The following is a description of a gene set: studied in species Homo sapiens from publication Chen Y, Wang X (PMID 31504780) Human Gene Set: MIR4766_5P Genes predicted to be targets of miRBase v22 microRNA hsa-miR-4766-5p in miRDB v6.0 with MirTarget v4 prediction scores > 80 (high confidence targets)., and this is the list of marker genes: MTMR4, NELL2 (neural EGFL like 2), RB1CC1, RFX3, CDK12, SH3BGRL2, SOX6, HIF1AN, INO80D, NOL4, ADAMTS17, PDLIM3, ELF1, SLCO6A1, SLC38A1, PARPBP, BAG5, SCAI, GUCY1B1, ZNF681, ATXN7, SLC18A1, FZD3 (NCBI Gene Id 7976), PRR23C, RTKN2, HCAR2, EPB41L2, CMKLR2, C8orf33 (chromosome 8 open reading frame 33), MORC1, SCUBE3, PKHD1L1, FAM210A, TLR5, OSTM1, LRCH2, RFXAP, ZNF350, CDK13, WNK3, GNE, UBIAD1, RTF1, PIGV, AMOT, ADD3, PHIP, AKAP11, TRANK1, FGFR2, SPRED1, SEMA3A, IDS, AAK1, TNKS2, STAM2, C5orf22, CSTB, GOLGB1, TMEM26, CEMIP, SPTY2D1, LNX2, SLX4IP, BCL10, PLCXD3, ZDBF2, GATAD2B, KCNA7, RCN2, ZNF626, KALRN, HMG20A, TTPA, BBX, CHD9, GOT2, KLHL14, ACADSB, CGGBP1, NCOA2, DPYS, RHOQ, MBLAC2, TAF9B, ARV1, REPS2, PHF20L1, WBP1L, FAM221B, SBSPON, ATP6V0A2, ATXN1, RAB22A, SASH1, PI15, C6orf62, RUNDC3B, SPICE1, TMEM263, IFT20, TFB2M, ZNF516, GAS7, TLN2 (NCBI Gene Id 83660), TOP1, VGLL3, DHTKD1, NSL1, GCOM1, PCDHGA11, ZMYND8, SLC1A3, ACTBL2, CADM2, ECT2L, DIP2B, TUBGCP3, DCDC2, TRIM13, RBM25, AR, SUPT20H, RPRD1A, MLLT10, BASP1, CLVS2, ACTN4 (NCBI Gene Id 81), SLFNL1, PAM, MARCHF6, ZFP90 (NCBI Gene Id 146198), XYLT1 (NCBI Gene Id 64131), GNB4, NSUN7, LCORL, TRIM14, OCLN, HOOK3, HPGDS, ZBTB20, LRP6, NNT, B3GALT1, SLC44A1, DNAJB3, MYBL1, IFIT2, FIGN, RND3, SNX27, AFF4, FTHL17 (ferritin heavy chain like 17), KICS2, ZNF236, SNX16 (sorting nexin 16), PPM1G, CREBRF, POU4F2, RASAL2, IFT81, SCAF11, GLYR1, AGBL3, ZNF195, ARL13B, SANBR, ARHGAP28, CBX5 (chromobox 5), UNC5D, ROBO1, KMT5B, CYB5R3, MAPK1IP1L, C14orf28, KCNN2, MGAT4A, BIRC5 (baculoviral IAP repeat containing 5), TMEM132D, MEMO1, FZD4, PRKACB, C21orf91, TMEM237, IMPACT, ZNF26, SH3PXD2A, PLEKHA1, STMP1, GPR158, MAP7D3, HLF, ZNF322, SIX4, MEIOC, BMPR1A, VEPH1, P2RY13, RBM4, GNAL, CDKL4, MYO3B, PAPLN, ZNF92, GLI3, SLC66A3, DOCK10 (dedicator of cytokinesis 10), ADAMTSL1 (NCBI Gene Id 92949), DDX20, MCTP2, ZFP36L1, AFF3, KLHL15, SYT14, CLGN, FAM98A, HYCC2, AUTS2, TRAM1, CHRNA4, TAOK1, DNAI4, HCAR3, NCKAP5, EEIG2, BACE1, RASA4, UTP25, ZBTB44, GUCY1A2, BOD1L1, PRDM10, GPBP1, TAF4, AMMECR1, PRR9, NACC2, SMG1, RELCH, JTB, DPPA2 (NCBI Gene Id 359786), GRM1, CLOCK (clock circadian regulator), FSIP1, RAD51AP1, GID4, RBMS3, PLD5, SV2C, CYP4X1, ADAM12, CEP97, PHTF2, ZBTB11, ZNF32, STOX2, SEH1L, SBF2, MTMR7, BRK1, TNFAIP8, ARIH1, NEDD9, GNPDA2, SLC4A4, DPP4, EDNRA, IRX1, LRP8 (LDL receptor related protein 8), CYP7A1, CCNT1, ZDHHC21, SRRM1, NFAT5, LAMC1, BRWD1, SMAD4, KCNJ10, ASB8, GTF2A1, PRPSAP1, STMN1, PPP4R2, PTAR1, HCN1, ING2, STXBP5, LRP2BP, ACVR2A, SLC30A4, OPRK1, ZNF142, HSPH1, NPAS2, SPX, CEP41, PDE4B, ZBTB7C, L3MBTL3, ZRANB1, PKN2, FBXL17, KAT2B, SUN1, POLR2M, ADAMTS16, MOCS2, SLC4A8, SDHD, ZNF257, ZNF460, GLCCI1, PCDH7, MOSPD1, SSR1, CAVIN4, ETNK1, TNFSF8, ZNF844, TEDDM1, MAPK9, MECP2, USP33